The following is a description of a gene set: studied in species Mus musculus Reactome Pathway: RNA Polymerase III Transcription Initiation From Type 3 Promoter part of: RNA Polymerase III Transcription Initiation This event has been computationally inferred from an event that has been demonstrated in another species.<p>The inference is based on the homology mapping from PANTHER. Briefly, reactions for which all involved PhysicalEntities (in input, output and catalyst) have a mapped orthologue/paralogue (for complexes at least 75% of components must have a mapping) are inferred to the other species. electronically inferred by orthology from the curated human pathway, and this is the list of marker genes: Polr2e, Polr1c, Polr2k, Polr2l, Tbp, Pou2f1, Polr3g, Crcp, Polr3d, Bdp1, Snapc3, Polr3c, Polr3e, Snapc1 (NCBI Gene Id 75627), Polr2f, Polr3h